The following is a description of a gene set: Mouse Gene Set: GOBP_ENDOCARDIAL_CUSHION_FUSION species: Mus musculus The cell-cell adhesion process of mesenchymal cardiac cushion cells that contributes to the process of cushion shaping., and this is the list of marker genes: Cplane2, Acvr1, Tgfbr2, Gata5, Tgfb2